The following is a description of a gene set: species: Homo sapiens A protein complex that is located in the endoplasmic reticulum and is composed of chaperone proteins, including BiP, GRP94; CaBP1, protein disulfide isomerase (PDI), ERdj3, cyclophilin B, ERp72, GRP170, UDP-glucosyltransferase, and SDF2-L1. Human Gene Set: GOCC_ENDOPLASMIC_RETICULUM_CHAPERONE_COMPLEX, and this is the list of marker genes: PDIA6, HSPA5, PPIB (NCBI Gene Id 5479), HYOU1, HSP90B1, DNAJB11, SDF2L1, UGT1A1, DNAJC10, MZB1, P4HB